The following is a description of a gene set: studied in species Homo sapiens Human Gene Set: WP_MODULATORS_OF_TCR_SIGNALING_AND_T_CELL_ACTIVATION Modulators of TCR signaling and T cell activation, and this is the list of marker genes: ZAP70, TNFAIP3 (NCBI Gene Id 7128), CDKN1B, CBLB, CD247, CD28, NDUFB10, RPRD1B, CD5, RELA, CUL5, CD8A, CARD11, DGKZ, RASA2, MEF2D, PIK3R2, UBASH3A, PLCG1, REL, GRB2, CD3E, PIK3R1, ITK, GNA13, ZFP36L1, MAP3K8, PTPN6, ARIH2, PRKCQ, SH2B3, LAT, GRAP2, CHUK, AGO1, LCK, AKT1, DGKA, VAV1, CD3G, MAP4K1, FIBP, NFKBIA, SMARCB1, TRAF6, IKBKG, SH2D1A (SH2 domain containing 1A), ELOB, RNF7, MAP3K14, IKBKB, PDPK1, NFKB1, LCP2, PCBP2, BCL10, RHOH, SOCS1, TMEM222, CD3D, MALT1